Given this list of marker genes Aim2, Pycard, Nlrp1b, Timm50, Hspd1, Bad, Nlrp1a, Nlrp3, here is a description of the gene set: Binds to and increases the activity of a cysteine-type endopeptidase. species: Mus musculus Mouse Gene Set: GOMF_CYSTEINE_TYPE_ENDOPEPTIDASE_ACTIVATOR_ACTIVITY